The following is a description of a gene set: Mouse Gene Set: MIR_3101_3P from publication Chen Y, Wang X (PMID 31504780) Genes predicted to be targets of miRBase v22 microRNA mmu_miR_3101_3p in miRDB v6.0 with MirTarget v4 prediction scores > 80 (high confidence targets). species: Mus musculus, and this is the list of marker genes: Cstf2, Gabrg2, Mcidas, Supt7l, Gria2, Zfp839, Ankrd27, Trpm1, Wipf1, Pdcd4, Dab2, Map4k5, Ctnnbl1, Trpm3, Mettl3, Ube2b, Tmem181a, Syt1, Tbc1d15, Rab23, Skil, Irak2, Zfhx4, Ube2k, Zfp786, Onecut2, Uty, Rap1a, Dkk2, Hoxc4, Cacna1h, Enpep, G6pc1, Stc1, Znrf3, Gcsam (germinal center associated, signaling and motility), Krba1, Bclaf1, Cdk13, Stk26, Paip2, Pip5k1b, Mthfd2l, Peak1, Plppr4, Tmcc1, Nkain3, Atp11a, Dscam, Slk, Wdr36, Atl1 (atlastin GTPase 1), Rbm12, Ahcyl2, Fryl, Ythdf2, Hus1, Ttc3, Eif5a2, Cers6, Tex16, Il6st, Atl3, Amer2, Cpeb4, Ralyl, Ppp1r14c, Kctd9, Crmp1, Itfg1, Camk1d, Fam184b, Clock, Ppp2r1b, Zfhx3, Fgfr3, Fam168b, Gcg, Msi2, Tex2, Hoxd1, Ralgapb, Gas2l1, Opn1mw, Lgr4, Anxa4, Serbp1, Kif21a, Cavin1, Eda, Ctnnd2, Cdr2, Hivep2, Unc80, Pde4b, Rnft1, Akap9, Arhgap6, Ror1, Car11, Cnp, Pabpc4l, Rfx4, Slc17a6, Pde7a, Smpd4, Them4, Ppp3ca, Sfi1, Bhlhb9, Cep170, Zfx, Rexo2, 1110032F04Rik, Rbm15, Timd6 (T cell immunoglobulin and mucin domain containing 6), Setd3, Ptprm (NCBI Gene Id 19274), Lsm14a, Krtap9-21, Chd1, Dlx3, Zkscan8, Nfe2l1, Meis2, Six3, Ly86, Kcnv2